The following is a description of a gene set: Enables the transmembrane transfer of a calcium ion by a channel that opens when glutamate has been bound by the channel complex or one of its constituent parts. Mouse Gene Set: GOMF_GLUTAMATE_GATED_CALCIUM_ION_CHANNEL_ACTIVITY studied in species Mus musculus, and this is the list of marker genes: Grin2b, Grin2c, Grik2, Grik1, Grik3, Gria1, Grin1, Grin2a, Grin2d, Gria3